Given this list of marker genes Cd24a, Elavl4, H2az1, Hnrnpc, Itgb6 (NCBI Gene Id 93831), Eml4, Stc1, Colq, Gpr174, Ncbp2, Abhd17b, Plag1, C5ar2, Macir, Tigd4 (NCBI Gene Id 403175), Ube2v1, Zik1, Ap3m2, Cnot6l, Vcpip1, Dynlt1b, Wdr7, Or8u3-ps, Rc3h1, Aurkb, Ankrd50, Arl14epl, Cdh2, Ikzf2, Cert1, Mob3b, Gpatch2, Foxp2, Farp1, Sinhcaf, Tesk2, Pacs2, Fnbp4, Sectm1b, Usf3, Ptbp2, Pdcd4, Rhot1, Dpm1, Lrrtm1, Snrk, Rffl, Ank (NCBI Gene Id 52488), Edar, Sec11a, Myef2, Klrg2, Fnip1, Slc25a51, Zeb2, Arglu1, Shisa6, Ccnj, Spns2, Jade1, Kdm7a, Sptssb, Sox5, 9330159F19Rik, Mapk6, Llph, Ddx1, Ggact, Sos2, Rcbtb1, Cramp1, Dgcr8, Reep1 (NCBI Gene Id 97333), Kpna3, Tmbim6, Zcchc14, Cd2ap, Stmnd1 (NCBI Gene Id 380842), Nat1, Mrpl17, Smim15, Usp24, Zfp975, Gata4, Osbpl1a, Tipin, Eif4g2, Rfesd, Tspan3, Zfp703, Cnpy1, Smr2, Sh3rf1, Setdb1, Atg14, Secisbp2l, Pls3, Sh3kbp1, Ptbp3, Wac, Pank1, Ube2v2, Srgap2, Sdc2, Pcdh15, Lyg2, Lrch2, Kitl, Fam184a (NCBI Gene Id 75906), Fyn, Bnc1, Col5a2, Omg, Nmt2, Vav3, Cebpg, Xrn1, Rcn2, Cgrrf1, Ptar1, Rab5c, Macroh2a1, Dnm1l, Ralyl, Ets1, Tmem106b, Rsbn1, Lpxn, Sox6, Gm5141, Atf2, Amot, Pgap1, Ddx5, Ankle2, here is a description of the gene set: species: Mus musculus Genes predicted to be targets of miRBase v22 microRNA mmu_miR_499_5p in miRDB v6.0 with MirTarget v4 prediction scores > 80 (high confidence targets). Mouse Gene Set: MIR_499_5P from publication Chen Y, Wang X (PMID 31504780)